Given this list of marker genes CYP24A1, CYP2R1, CYP27A1, CYP27B1, CYP3A4, here is a description of the gene set: species: Homo sapiens Conversion of vitamin D3 from its largely inactive form (calciol, also called cholecalciferol) into a hormonally active form (calcitriol). Conversion requires 25-hydroxylation of calciol in the liver to form calcidiol, and subsequent 1,alpha-hydroxylation of calcidiol in the kidney to form calcitriol. Human Gene Set: GOBP_CALCITRIOL_BIOSYNTHETIC_PROCESS_FROM_CALCIOL